The following is a description of a gene set: species: Homo sapiens Human Gene Set: HP_ABNORMAL_MORPHOLOGY_OF_THE_MUSCULATURE_OF_THE_NECK Abnormal morphology of the musculature of the neck An abnormality of the neck musculature., and this is the list of marker genes: ATP1A3, SCP2, ACTA1, TSPOAP1, KMT2B, KCNC3, VPS13D (NCBI Gene Id 55187), PRKRA, SOX10, ALG9, MYF5, SUPT16H, TRPM3, COL6A3, COLEC11, TMEM151A, COL25A1, KIF21A, PNKD, GDAP2, B3GALT6, RNF170, ROBO3, CP, GRIK2, DRD2, MYT1L, KIF1C, TBP, PRDX3, KCNN2, PRRT2 (NCBI Gene Id 81865), TOR1A, SPG11, TUBB4A, MAPT, ANO3, COX20, NAA10, TUBB3, SIGMAR1, COL6A2, MEOX1, ALS2, FLI1, SGCE, GDF3, PCGF2, TRPV4, CIZ1, ATP13A2, ZNF142, PRKAR1B, NEK9, NKX6-2, PPP2R5D, CDK10, FUS, HPCA, KCTD17 (potassium channel tetramerization domain containing 17), PHLDB1, SPTBN1, NR4A2, IMPDH2, GDF6, SPTLC1, TUBB2B, ITGA7, TGFB2, VPS11, DDC (NCBI Gene Id 9492), NAXE (NAD(P)HX epimerase), GNAL, CACNA1A, TGM6, CNP, SYNGAP1, THAP1, VPS16, FOXP2, COL6A1, TUBA1A (NCBI Gene Id 95407), COL12A1, GCH1, HK1, CEP85L, PHOX2A